Given this list of marker genes TLCD2, MS4A10, REEP6, ACTN4, AOC1, C8G, BAIAP2L2, BMP1, FBLIM1, ITSN1, CTSD, SPINT1, SLC13A2, PLAAT2, TMC5, PNPLA2, GPX4, SLC19A1, H1-2, CAMK2N1, MAF, INF2, SLC15A1, GLTPD2, APOA1, ALDOB, SLC9A3-OT1, CYP2B7P, VEGFA, SLC22A18, MTTP, AHNAK, SEMA6C, LPIN2, APOB, NR0B2, SERPINA1, SLC3A2, YPEL3, TRPV6, PEPD (NCBI Gene Id 84738), GSDME, ARHGAP27, RHOC, HLA-DRB1 (NCBI Gene Id 730415), TBX3, MISP, COL17A1, SSUH2, SLC6A19, S100A6 (S100 calcium binding protein A6), ENPP7, SEMA3B, HLA-DRA, IGFBP4, MYO7B, KLF4, LMO7, CDKN1A, GPCPD1, SLC6A20, HERC4, SLC28A1, CYP2S1, SAT2, ACSL5, CSNK1D, SLC9A1, SLC2A5, FBP1, INPP5J, C1QTNF12, LRP1, DGAT1, SMPD3, LINC01133, TNFRSF1A, ADH4, XPNPEP2, APOA4, LAMB3, C2orf88, MALL, EPS8L2, EZR, S100A14 (NCBI Gene Id 57402), CREB3L3, RAB17, CGN, MXD1, S100G, MGLL, GPA33, SLC4A7, TMPRSS15, SLC12A7, CYP1A1, PLIN2, ANPEP, SSX2IP, HKDC1, UGT2B7, CIDEC (NCBI Gene Id 63924), TM6SF2, TJAP1, RMDN3, CYP2C9, ARHGEF16, ABCC3, ZBTB7B, VILL, RND3, MIGA2, IFI27, DNASE1, ATP2B1, ANGPTL4 (NCBI Gene Id 93954), SREBF1, NHERF4, TM4SF4, MDK, SECTM1, ECHDC2, TIMP2 (TIMP metallopeptidase inhibitor 2), NPC1L1, CARD10, SLC25A37, HHLA2, ALPI, SLC28A2, ARL14, HAPLN4, SLC17A4, GPAT3, CD74 (CD74 molecule), SULT1A2, FBXW5, MGAM (NCBI Gene Id 8972), SLC36A1, AMN, ANKRD9, MME, HOOK2, POR, CYP4F12, RIOK3, CTSE, CD36, TRIM15, PTPRF, HSPB1, SLC26A3, ACE (angiotensin I converting enzyme), IL6R, ADIRF, SLC39A4, ATP8B2, EPS8L3, DGKA, ACY3, CRYBG2, SPATS2L, PTPRH, ABCG2, SLC5A9, CYP4F2, LAMA3, MS4A8, SLC5A1, PLS1, PAXBP1, MUC13, CES2, TRIP10, AFDN, UACA, ACHE, IL32, MICAL1, GALNT6, NPNT, MYH14, SLC46A1, SELENOP, MIA2, CYP3A4, AAK1, PRODH, MUC17, GALE, SLC6A8, ADA (NCBI Gene Id 100), FLVCR1, IGSF9, GSDMB, ACOX1, ZSWIM8, ABCC2, GABRE, SGK1, TENT5A (NCBI Gene Id 55603), CYP2C18, PCK2, POLD4, ANK3, ACADVL, ENPP3, TREH, MTMR11, CDHR5 (NCBI Gene Id 55618), ACAA1, GADD45B, SMIM24, PLXNB2, ENPEP, ITGB4, APOC3, TMEM253, FLNB, MEP1B, MAPK3, AQP10, PAQR7, MICALL2, CIDEB, TM4SF5, SLC27A4, RAPGEFL1, FABP2, C11orf86, CYP3A5, TM4SF20, CDHR2, SLC40A1, PLEC, CD151, ABHD3, PRAP1, KLF6, ABCG5, PFKP, MYO1A, AGPAT2, DGAT2, OGDH, SCARB1, AATK, MPP1, PCK1, C3orf85 (NCBI Gene Id 401081), ATG4B (autophagy related 4B cysteine peptidase), P4HB, STAT6, LCT, SCNN1A, PHGR1, ACE2, MFSD2A, CEACAM6, here is a description of the gene set: species: Homo sapiens from publication Busslinger GA, Weusten BLA, Bogte A, Begthel H, Brosens LAA, Clevers H (PMID 33691112) Human Gene Set: BUSSLINGER_DUODENAL_MATURE_ENTEROCYTES